The following is a description of a gene set: species: Mus musculus A process in which non-proliferating myoblasts fuse to existing fibers or to myotubes to form new fibers. A myoblast is a mononucleate cell type that, by fusion with other myoblasts, gives rise to the myotubes that eventually develop into skeletal muscle fibers. Mouse Gene Set: GOBP_MYOBLAST_FUSION, and this is the list of marker genes: Nfatc2, Ntn3, Myh9, Cacna1s, Dock5, Ripor2, Tmem182, Gsk3b (glycogen synthase kinase 3 beta), Gdf15, Mapk14, Synb, Adgrb1, Flt3l, Igfn1, Scgb3a1, Myod1, Ehd2, Mymk, Wnt1, Syna, Tanc1, Cd9, Cxcl10, Nphs1, Plekho1, Cflar, Flot1, Cd81, Il36g, Dock1, Mymx, Adamts5, Cd53, Ptgfrn, Itgb1, Il4, Ins2, Cxcl9, Il4ra, Myog, Dock2, Cxcl12, Neo1, Cav3, Adamts15, Cdon, Adgrb3, Dyrk1b, Capn2, Casp1, Ccl8 (C-C motif chemokine ligand 8), Tnfsf14, Ehd1